Given this list of marker genes Wnt5a, Ptk2, Mdga1, Epha7, Gsk3b, Ptpn13, Robo1, Dkk1, App, Clstn3, Slit1 (NCBI Gene Id 226119), Tlr2, Rhoa, Cbln1, here is a description of the gene set: Mouse Gene Set: GOBP_NEGATIVE_REGULATION_OF_SYNAPSE_ASSEMBLY Any process that stops, prevents, or reduces the frequency, rate or extent of synapse assembly, the aggregation, arrangement and bonding together of a set of components to form a synapse. studied in species Mus musculus